Given this list of marker genes SOX9, BRAF, RAD51C, SDHC, AKT1, SLC6A17, WRN, SMAD4, SETBP1, GATA2, HABP2, BRIP1, MC2R (melanocortin 2 receptor), WWOX, RPL31, CYP11B1, KLLN, RPS19, TFE3, CDKN2A, DIS3L2, KIT, RPS20, HRAS, GPC4, BMPR1A, BARD1, TSC1, NAB2, SMARCB1, DHH, GATA4, GNAS, RPL27 (ribosomal protein L27), PAX6, NTHL1, RPL35, PBRM1, BUB3, PRCC, KRAS, COQ6, EPHB2, MDH2, RAD50, MLH1, LMNA, FLCN, SEC23B, FERMT1, VAMP7, ATP7A, BRCA2, RPL9, POU6F2, APC2, MNX1, MBD4, NBN, KCNQ1OT1, PTPN12, STK11, TGFBR2, PTEN, ARMC5, CTNNB1, TSR2, SUFU, PLA2G2A, PRKN, CEP57, SDHA, PRKAR1A, RPL11, MCC, CREBBP, H19, RPL35A, MSH2, COL4A6, TSC2, IDH1, HNF1B, MXI1, TRIM37, COL4A5 (collagen type IV alpha 5 chain), DLC1, MET, LZTR1, RNASEL, HDAC4, COL14A1, HEATR3, RPS28 (ribosomal protein S28), MVK, RPL5, STAG3, MSH3, RET, CDKN1C, MSH6, RPL15, GPC3, PRDM10, PTCH1, MRAP, PMS1, KCNQ1, ERBB2, SLC25A11, SDHAF2, BMPER, POLE, C1S, PDE11A, ADA2, BAX, RAD51, TRIP13, RPL8, RAD51D, DHX37, OGG1, SMARCA4, SDHB, SPRED1, RNF43, TP53, STAR, RAD54B, STAT6, STS, WT1, EP300, USF3, B3GALT6, AXIN2, FGFR3, REST, MLH3, CXCR4, BCL10, NNT, PIK3CA, DOCK8, FIBP, PMS2, ALX4, FLI1, CHEK2, RPS10, PTPRJ, TLR2, AURKA, EWSR1 (NCBI Gene Id 2130), NR0B1, BAP1, GATA1, RPS24, ATM, BUB1B, MAX, NF2, PHF21A, IDH2, SDHD, OPCML, SEMA4A (semaphorin 4A), RABL3, TMEM127, ASXL1 (ASXL transcriptional regulator 1), NOD2, KDM1A, TXNRD2, FH (NCBI Gene Id 83748), CDH1, RPL26, NF1, PDGFRL, RPS15A, WNT10A, MAD1L1, MINPP1, KEAP1, BLM, NRAS, DLST, RPL18, MAP3K1, DICER1, AR, IFNG, NR5A1, DCC, MRE11, RNF139, SRY, CDC73, KLF6, KANSL1, TRIM28, CDKN1B, RB1, IGF2, RPS27, ZFHX3, RPS26, EPCAM, PALLD, POLD1, EXT2, SRC, AAGAB, HNF1A, PALB2, MDM2, MUTYH, NSD1, KIF1B, RPS29, BRCA1, ZFPM2, FOXE1, RPS7, VHL, GREM1, APC, ZFTA, RPS17, PTCH2, FGFR2, CCND1, BUB1, here is a description of the gene set: A tumor (abnormal growth of tissue) of the genitourinary system. studied in species Homo sapiens Neoplasm of the genitourinary tract Human Gene Set: HP_NEOPLASM_OF_THE_GENITOURINARY_TRACT